Given this list of marker genes IL12RB1, PPRC1, RPA2, RPL14, FARSA, DYRK3, RPL9, CD74, DDX21, PTPRC, SERBP1, RPS2, CD69, MAP4K1, SPI1, HNRNPA1 (heterogeneous nuclear ribonucleoprotein A1), CD79A, ITGA4, MRTO4, HK2, GNL3, RPL6, RPS10, RPS9, PPAN, RSL1D1, NAP1L1, NLRP3, ABCE1, MAP3K7, ITGB2 (integrin subunit beta 2), HNRNPC, SRGN, CD38, BCAT1 (NCBI Gene Id 586), IL2RA, RPLP0, IMPDH2, MYC, SLC25A3, HCLS1, LAS1L, RPS6, HLA-DQA1, CD86, RPS3, FBL, WAS, EIF3A (eukaryotic translation initiation factor 3 subunit A), FCGR2B, NPM1, RPS5, PRKCB, RPL34, here is a description of the gene set: Human Gene Set: BEAUCHAMP_MISS_54_MYRISTOYLATION_INHIBITION_SENSITIVE_SIGNATURE This gene set consists of genes (MISS-54) whose expression correlates with cancer cell sensitivity to N-myristoyltransferase inhibition (NMTI). Transcriptomic analysis of 1200 NMT inhibitor (NMTI)-treated cancer cell lines revealed that NMTI sensitivity relates not only to NMT2 loss or NMT1 dependency, but also correlates with a myristoylation inhibition sensitivity signature comprising genes (MISS-54) enriched in hematologic cancers as well as testis, brain, lung, ovary, and colon cancers. Because non-myristoylated proteins are degraded by a glycine-specific N-degron, differential proteomics revealed the major impact of abrogating NMT1 genetically using CRISPR/Cas9 in cancer cells was surprisingly to reduce mitochondrial respiratory complex I proteins rather than cell signaling proteins, some of which were also reduced, albeit to a lesser extent. Cancer cell treatments with the first-in-class NMTI PCLX-001 (zelenirstat), which is undergoing human phase 1/2a trials in advanced lymphoma and solid tumors, recapitulated these effects. The most downregulated myristoylated mitochondrial protein was NDUFAF4, a complex I assembly factor. Knockout of NDUFAF4 or in vitro cell treatment with zelenirstat resulted in loss of complex I, oxidative phosphorylation and respiration, which impacted metabolomes. Genes upregulated in cancer cell lines sensitive to N-myristoyltransferase (NMT) inhibition species: Homo sapiens from publication Beauchamp E, Gamma JM, Cromwell CR, Moussa EW, Pain R, Kostiuk MA, Acevedo-Morantes C, Iyer A, Yap M, Vincent KM, Postovit LM, Julien O, Hubbard BP, Mackey JR, Berthiaume LG (PMID 38715059)